The following is a description of a gene set: Human Gene Set: CUI_DEVELOPING_HEART_5TH_WEEK_VENTRICULAR_CARDIOMYOCYTE studied in species Homo sapiens from publication Cui Y, Zheng Y, Liu X, Yan L, Fan X, Yong J, Hu Y, Dong J, Li Q, Wu X, Gao S, Li J, Wen L, Qiao J, Tang F (PMID 30759401), and this is the list of marker genes: MCEMP1, TMEM185A, NR2F1-AS1, AIF1L, MYH6, EGR2, ULK4, COL2A1, HSDL1, EPM2AIP1, RAB9B (NCBI Gene Id 51209), HEY1, ABRA, LINC00842, DUSP2 (NCBI Gene Id 1844), RABGAP1L, CLIC5, SLC30A3, PJA1, RELN, GPX3, NPPB, FOS, PGAM2, ADM, SH3KBP1, PREP, CALB2, INTS6L, DESI1, PAM, VWDE, KLK6, DKK3, MYBPHL, DUSP14, PDLIM4, TUBB6, FEZ1, EHD4, CNN1, BAIAP2L1, ACTA1, ZFP36, NTF4, ZNF385B, SORD, CIMAP3, CREB3L2, TESC, PDE8B (phosphodiesterase 8B), DES, H2BC21, ATP2A2, B3GNT2, BVES, FAM78A, SHISA5, LINC00938, ITM2A, WNK1, SYNPO2L, GJA5, TECRL, DUSP5, HAND2, NR2F2-AS1, RHOD, GATM, PPP2R2B, IGFBPL1, STAR, SVIP, SMCO4, PDLIM3, CPE, ELAPOR2, CPNE5, MARCHF3, VSNL1, NR2F1